The following is a description of a gene set: studied in species Homo sapiens Genes predicted to be targets of miRBase v22 microRNA hsa-miR-939-5p in miRDB v6.0 with MirTarget v4 prediction scores > 80 (high confidence targets). Human Gene Set: MIR939_5P from publication Chen Y, Wang X (PMID 31504780), and this is the list of marker genes: BARHL1, KRT3, PA2G4, UBE4A, NACC1, GRN, TRIM3, C3orf18, LOXL3, UBIAD1, TMBIM1, CBX7, SH3PXD2A, VAT1, PIRT, NGFR, RAB1B, MYLK2, SCN4B, COL5A3, LSAMP, LNX2, GRM4, ARID3B (NCBI Gene Id 10620), KLHL3, GPD1, TRIM66, COX10, NOS2, CTIF, KDELR1, FAM193B, PAX5, OLFML2A, PDZD7, PRKACA, KRTAP10-5, PRX, NOVA2, VAMP2, BCAS1 (brain enriched myelin associated protein 1), FOXP4, RPS23, RPS24, DHRS11, POLE3, CLCN7, RIMS3, USP22, CDK10, NAT16, NAAA, RARA, WNK3, SLC25A45, CAVIN1, DENND6B, SCN4A, TNF, ZBTB4, PROX1, RNF130, ALDH7A1, C20orf203, PRKAR1B, IFT140, ERAL1, SLC34A2, HLA-DRB1, SPATA31C2, PEAR1, TEAD1, PADI2 (peptidyl arginine deiminase 2), PCDHGA12, PFN1, TAB1, SCARA5, MTCL2, S1PR2, MPIG6B, KIF1A, TAL1, SPINDOC (NCBI Gene Id 144097), LCN1, LRRC25, SCAMP4, CDR2L, C22orf46P, BTBD9, NDST3, CSNK1A1, CDKN1A, IQSEC3, NCDN, GRIK3, SHISA6, ZNRF1, HECTD3, MECP2, SFT2D3, ETV4, SPTB, SYNGAP1, CSPG4, KCNK5, CDC42BPA, NFASC, NHERF2, CD4, PPT2, STIM1, SIAH3, RIMKLA, FBLN5, EPB41L1, SP6, MN1, TWNK, TBC1D16, HS6ST1, TTYH3, CIB2, SRGAP1, FIS1